Given this list of marker genes TDRKH-AS1, RABGAP1L-DT, JOSD1 (NCBI Gene Id 9929), HMX3, SRSF1, GFER, TMEM14B, SUMO3, SEC14L1, PRPSAP1, WDR1, MIER1, PAFAH2, DGCR8, CBX4, RNU5B-1, ZNF222, USP33, RNA5SP60, RAB5IF, LINC01287, GTF2H4, MIR223HG (MIR223 host gene), PPP1R15A, CHCHD2, AGPS, TMEM128, MAPKAPK5-AS1, PPP1R3E, GNA15-DT, SAP30, NADK2, SH3TC1, PEDS1, AHCYL2, CLTC, TMEM69, RNU6-1276P, ARPC5, SULT2B1, PPP1R12C, MIR4766, ARL5AP5, RN7SKP91, ARHGAP24, SLC8B1, RN7SKP192, LINC01732, SLC7A7, SYCN, SH3BGR, ZNF649, RABGAP1L, IMPACT, ANKZF1, MIR4733HG, BIRC5, NAPEPLD, IFNAR1, POPDC2, RNU4ATAC, NOSIP, PCK1, MAP1LC3B2, ZNF224 (zinc finger protein 224), KBTBD6, MPV17L2, BANP, RNU6-377P, SREBF2, ZNF337, RAB4A, WBP1, SOSTDC1, C10orf95-AS1, ATP5MC1, RNU6-1216P, SKIL, TERF2, ACSM3 (acyl-CoA synthetase medium chain family member 3), BCAT1, MT-TW, EBF1, BIN1, IL23A, ADNP, ZNF217 (NCBI Gene Id 7764), AGL, SNHG32, ENSG00000263571, RN7SKP235, TTC1, PTBP1, RPL29P20, PXN, SLMAP, CDH23, WWP1, CREM, MATN1-AS1, RNA5SP52, LINC01521, BOD1, WASF1, SPTBN4, GLB1 (galactosidase beta 1), LINC01898 (long intergenic non-protein coding RNA 1898), HERC1, MACROH2A1, SCAMP5, PLEKHF2, ZBTB38, PTK2, GSPT1, VPS29 (NCBI Gene Id 51699), ENSG00000253986, TMIGD3, SYNRG, MT-TR, TBL1X, B3GNT5, ZFYVE27, NR4A1, LINC00607, CADM3-AS1, TMEM161B, CLPB, NMRAL1, CDYL, APP, NDUFS2, CCZ1P1, RBBP4, HS1BP3-IT1, ABCA17P, ENSG00000238142, MIR4645, LRRC41, SF3A3, MASP1, GALE, LINC01719, TOR1A, TSSC4, SNORD25, LINC02252, MRFAP1L1 (NCBI Gene Id 114932), DHRSX, RNF130, ABCC3, PITHD1, ACVR1B, RFFL, ADGRB3-DT, C12orf43 (NCBI Gene Id 92582), CEPT1, TCEA2, UBE2E2-DT, AAMP, ENSG00000250274, CSTF3-DT, MAGOH2P, MT-RNR2, DOCK7, ZSCAN31, CFAP99, MT-CO1, NAV2 (NCBI Gene Id 89797), ZNF341-AS1, MKRN3, FARSA, CCDC174, RAB30, GUSBP18, MARCHF2, WDPCP, SSMEM1 (serine rich single-pass membrane protein 1), NDUFS7, WWTR1, SEPTIN4, SMARCD3, STRIP1, TAL1 (NCBI Gene Id 6886), ACTB, IFT20, TXNDC15, SMIM13, STARD10, OTUD7A, HMBOX1, DSTYK, DHX40, CTB-30L5.1, KBTBD6-DT, ARHGEF12, ENSG00000223598, FOXN4, LINC02543, RIN3, RPL8P5, C2CD5, ATG9A, TMEM245, TSSK3, MTR, ADD1, NR3C1 (NCBI Gene Id 389335), NSD1 (nuclear receptor binding SET domain protein 1), RPL13AP8, SLC9A1, CRTC2, VARS2, CLEC16A, RNU1-108P, MUS81, RPL27, VGF, KNTC1, AMBRA1, DDX17, MEF2C-AS1, LINC02345, ZCCHC8, LNCATV, MIR3124, ERP44, PNISR, LCOR, DNAJB2, RAD51C, KIF15, TLR6, PRR11, ATF3, CCDC137, PATZ1, GNG4, CWC22, KIAA1143, LYPLA1, RUNX1T1, SMARCAD1, MRPL52, NAGLU, SCG3, LINC02122, ANKS6, MTMR4 (myotubularin related protein 4), AHI1, OIP5-AS1, SRP72P2, REXO2, XKR9, NTPCR, MIR3649, COMMD5, ENSG00000206898, CCT6B, CMTM3, BLOC1S4, MARS1 (NCBI Gene Id 4141), RPP14, GAB2, HMOX2, STX3, PHF8, SLK, MYO5B, EPC1, SLC39A13, MYL12-AS1, SEC24C, NFE2, AHNAK, CASK, UBE2O, DFFA, RNU6ATAC32P, SLC4A11, NFIX, PROSER2, KBTBD7, CYP2R1, GTF2IRD1, HES4, LINC02928, IGF1R, CARD8-AS1, ATP2B4, PTGES3P2, GAPVD1, TPM4, CALM3, SZRD1, ANO4, GLRA1, UBALD2, TMEM209, ADAM15, EEF2K, GNL3L, UBA5, GRK6, KDM7A-DT, RAB1A, LINC02985, TMPPE, ENSG00000221040, NSD3, CYB5R4, CCDC159 (coiled-coil domain containing 159), ITGAL, PPM1A (protein phosphatase, Mg2+/Mn2+ dependent 1A), CASS4, SH3BP5L, SPRR2D, CPNE2, SH3GL1, MANEAL, CTTN, UBE2E2, C19orf38, MAZ, PEMT, SCARNA2, GAREM2, BMAL1, GDF2, ZMYND8, ZSCAN2-AS1 (NCBI Gene Id 105370947), USF1, WBP2, MIR4729, SFT2D2, ENSG00000234022, CP, PRKAG1, SNF8, MFAP3L, RRP1B, ACTG1, AP3M2, ACSL6, SLC7A5P1, NDUFA4, ABHD5, EGFLAM, C19orf44, TULP2, SNAP25-AS1 (SNAP25 antisense RNA 1), EPC1-AS2, CRYBG2, LUC7L, BLTP2, EOGT, WTAP (NCBI Gene Id 9589), RPL19P16, DHX58 (NCBI Gene Id 79132), SCNM1, MYL12B, ENSG00000213963, RPL36AP19, SLC4A2, FBXW11, ENSG00000253887, FCHSD2, PMS2, IRF2BP2, HTD2, IFTAP, CFL1, ARAP1, OAZ1, MGRN1, MIR6841, PHF12, NCOA3, ATP5F1D, CCT3 (NCBI Gene Id 7203), CHCHD2P1, KCNAB1, FBXO15, BABAM1, LARS1, LNCTSI, GON4L, SCRT1, BARHL1, ZFYVE1, RNU6-218P, SNORD3J, FZD3, KHSRP, TH2LCRR, PLP1, PRDM5, DPY19L4, CXCL2, KCNH6, TIMM21, USP10, HSPA9, TARBP2, WDR46, MYO18B, MILR1, LASP1, SUMO2, RIC8B, FAM83A, MDH1, ATP6V0A1, PCSK6-AS1, C1orf174 (chromosome 1 open reading frame 174), NINJ2, MT-TG, SIAH1, OR8Q1P, ENSG00000232124, TSNAXIP1, GGT1, ARL14EPL, C16orf95, KCNMB2, ST6GALNAC4, ACP2, ARHGAP25, PPFIA4, PNKD (PNKD metallo-beta-lactamase domain containing), YIF1B, KDM7A, NR1H3, MTMR9, AGER, RNU12, CRPPA-AS1, VILL, DCTN2, UBE2E3, SMARCAD1-DT, ARL4A, STAU2, AIMP2, PPRC1, FGGY, CHMP3, RNU6-951P, ASIC4, LINC02695, LINC01756, TMEM115, ENSG00000228395, CAMTA1-DT, ZFP37, ZNF350, ZC3H7A, DNHD1 (NCBI Gene Id 387750), SAMD9L (NCBI Gene Id 4827), GABRB3, DDX23, SEZ6, SAMSN1, SAP30-DT, RFX1, METTL3 (NCBI Gene Id 95719), RAB30-DT, RFC1, VDAC2, KPNB1-DT, HSF2BP, CALCOCO1, SRP19, FKBP8, SNX19 (NCBI Gene Id 9795), CCDC137P1, LINC02842, CDCA3, SLC39A3, PSMA3-AS1, SNX12, STAU1, VPS37B (NCBI Gene Id 79720), MAPKAPK5, GRB10, MUC20-OT1, PGP, ENAM, MIR7-3, MT-TQ, SAE1, MGC4859, LYSMD1, PTDSS2, CPEB2-DT, PPA2, SMARCA4, RNU6-307P, IKBKB-DT, LRP6, ARHGDIA, STMN1, SDF4, HIKESHI, IKZF2, EVI5, LINC03023, MYCL, LINC00426, SIRPD, LINC02288, UQCRH, PKD1L2, MAPK8IP2, POLDIP3, NOXO1, ELF2P2, APH1B, KMT5A, OPLAH (NCBI Gene Id 55579), UBE2V1P4, CTTNBP2, MAG, ZNF225 (zinc finger protein 225), IL1R1, FAM83A-AS2, CCAR1, LRBA, MT-ND4, XIST, CCDC88A, C6orf62, SNHG5, TLR1, NPEPPSP1, ZBTB14, EPC1-AS1, PPP4R1L, PCSK6, MTND6P4, BRWD1, DRAM2, FEM1A, PUM3, ENSG00000199851, EBAG9, THADA, ZBTB17, MEF2C, HDAC6, CCDC124, ANO7, SRD5A3-AS1, H4C8, ZNF484, RNU5E-1, ARRDC3, RAB4A-AS1, LINC00235, MXD1, AMMECR1, NPEPPS, RUFY1, PIPOX, GHITM, RN7SKP249, FADS1, TM9SF4, FBXO38-DT, SLC25A12, ANO10, ISG20, MIR4736, ARPC2, RNA5SP89, DNAAF5, HMGB1, RPIA, FAM131B-AS2, PDE7A, MPND, TDRKH (tudor and KH domain containing), HTR5A, CLSTN1 (calsyntenin 1), SLC5A6 (NCBI Gene Id 8884), CD24, C2CD2L, CHMP4B (charged multivesicular body protein 4B), RIPOR3 (NCBI Gene Id 200230), ZYX, ABCA3, ISG15, SFSWAP, SNORD26, TCL6, COG3, SLC48A1, GNB4, PLAUR, MT-TV, TIPRL, EZR, FAM170B-AS1, LINC01353 (NCBI Gene Id 100506775), SNORD48, MAN2A2, B3GAT3P1, ADGB, DPAGT1, SEMA4B, MAPK13, VPS13C-DT, CALB1, PPP2R3B, ATF7IP2, IQCN, C17orf58, ZNF280D, AP2A2, ARMH4, FBXL21P, KCNK1, TASOR2, ST3GAL2, CAPN15, GPATCH8, ALKBH8, SPI1, VRK1, LEISA1, UBE3C, GALM, STAT5B, CARD8, IFRD2, JOSD2 (NCBI Gene Id 126119), CNOT10, CCDC25, S100Z, PPM1E, CALR3, MAK16, C3AR1, LINC00958, MT-ND4L, INVS, TP53RK, CDK5RAP2, CXXC1, ANKRD17, SIGLEC27P, CCNL1, USP31, RN7SKP116, VPS33B, ANKRD65, COX7C, ZNF280C, MCTS1, TOMM40L, TMEM11, TFEB, RHBG, ANKRD42, BANCR, SNX10, AP2S1, UFL1, NPL, RAB7A, NIFKP7, RSBN1, NELFE, CPEB2, FASN, TBX6, TMEM11-DT, QTRT1P1, ADAM9, SCRIB, NFE2L2, SKIC2 (SKI2 subunit of superkiller complex), BCL7C (BAF chromatin remodeling complex subunit BCL7C), TRIB3, CAND1, LINC02863, FAXDC2, LINC00620, INTS9, TNKS, ALKBH7, C3orf86P (chromosome 3 open reading frame 86, pseudogene), RNA5SP96, IKBIP, MT-ND3, UBC, ESYT2, ACIN1, GYPE, CAMTA1, ANXA11, C2CD3, CLP1, TRIM29, KRT18P33, ZCCHC7, USP9X, CDC40, SCAF1, GFUS, ENSG00000254718 (novel transcript, antisense to  PPM1A), STX4, ADGRB3, ZNF444, PXT1, TEAD1, C1orf74, DYNC1I2, PRKAB2, KNL1 (NCBI Gene Id 57082), JAM2, PPP5D1P, PSEN1, ALG6, YWHABP2, PNPLA6, MELK, TILAM, NFE2L1, MFAP1, SNHG1, VPS41, ALPK1, SLC22A18, SMPD4P1, ENSG00000212144, MIR202HG, LINC01258 (NCBI Gene Id 101928776), SKA2, NCOA6, MAD2L1BP, ANP32A, SUGP1, HM13, RANGAP1, TSC22D1, BSX, SHLD1, C1orf159, TEDC1, TM2D2, STAP2, ZBTB8OS (zinc finger and BTB domain containing 8 opposite strand), VPS35L, GPBP1L1, LEMD2, CAMKK2, TPGS1, TUFT1, CHD2, TNFAIP1, RALGDS, SYNPO, SUZ12, TKT, SLC14A1, MKKS, ENSG00000263280, CACTIN, YEATS2, ENSG00000232884, SLC7A5, SAMD4A, LINC01629, UBE2E3-DT, CUL5, ZNF460 (zinc finger protein 460), KRTAP2-4, EIF3B, XYLT2, CLPX, MIR7-3HG, SNHG20 (NCBI Gene Id 654434), MYO3B-AS1, MLLT10, PEDS1-UBE2V1, TUBB2A, NUMA1, VPS33B-DT, FAM168B, ZFYVE28, PLAU, SMO, YPEL4, DDX3X, RAD9B, LINC02777, LINC00668, WSB1, CABIN1 (calcineurin binding protein 1), PRKCE, LINC01397, KPNB1, ENSG00000215156, ABCF3, CEP131 (NCBI Gene Id 22994), LACTB2, NSMAF, RPRD1B, PRR5, SPINK4, KIF2A, FBXO38, SCOC, NDC1, THRB-AS1, TELO2 (NCBI Gene Id 9894), P4HB, CLASP1, UBAC1, APBB1, ALG1L13P, ERI1, AKR1E2, PI16, DIXDC1, TMED1, MYH9, TEX14, LINC02578, CSTF3, JSRP1, PRKCH, SLC3A2, ARID4A, LRRC61, SLX4IP, APAF1, JMJD1C, PCBP1-AS1, SPTAN1, FLYWCH1, UCKL1, CEP290, GAS8, UTP11, STC2, ING4, CHST10, PAK1, TANC1, MIR130AHG, PANK4, TRMT12, ADORA3, LEPROTL1, STXBP5-AS1, SLC25A6, NUP210, SETD4, PPEF1, BRD2, PVT1, MAU2, LSM10, TCERG1, PHB1, SCAND3, TMTC3, FCGR2A (NCBI Gene Id 90764), KCTD20, ZNF225-AS1 (ZNF225 and ZNF224 antisense RNA 1), HEMGN, ASAP3, RANBP10, here is a description of the gene set: Genes containing one or more binding sites for (ZNF175) in their promoter regions (TSS -1000,+100 bp) as identified by GTRD version 20.06 ChIP-seq harmonization. Human Gene Set: ZNF175_TARGET_GENES studied in species Homo sapiens from publication Yevshin I, Sharipov R, Kolmykov S, Kondrakhin Y, Kolpakov F (PMID 30445619)